The following is a description of a gene set: Reactome Pathway: KEAP1-NFE2L2 pathway species: Homo sapiens The KEAP1:NFE2L2 (KEAP1-NRF2, Kelch-like ECH-associated protein 1-Nuclear Factor (erythroid-derived 2)-like 2) regulatory pathway plays a central role in protecting cells against multiple homeostatic responses including adaptation to oxidative, inflammatory, metabolic, proteotoxic and xenobiotic stresses. The NFE2L2 transcriptome has been implicated in protection against many chronic diseases including cardiovascular, metabolic, neurodgenerative and respiratory diseases. In cancer, NFE2L2 plays a critical role in the metabolic reprogramming, directing metabolic intermediates into the Warburg and pentose phosphate pathways to support proliferative growth and redox homeostasis<br><br>KEAP1 is a redox sensor that together with CUL3/RBX1 forms part of an E3 ubiquitin ligase, which tightly regulates the activity of the transcription factor NFE2L2 by targeting it for ubiquitination and proteasome-dependent degradation. Oxidative modifications or electrophile adduct formation with redox-sensitive cysteines within KEAP1 renders this protein unable to target bound NFE2L2 for ubiquitination and allows newly translated NFE2L2 to accumulate within the cell and translocate to the nucleus where it can promote its transcriptional program.<br> part of: Cellular response to chemical stress, and this is the list of marker genes: CSNK2B, BRCA1, PSMD13 (proteasome 26S subunit, non-ATPase 13), SKP1, GSTA3, EP300, PSMC4, FBXL17, PSMA6, PSMD2, KEAP1, ADRM1, TRIM21, CSNK2A2 (NCBI Gene Id 650690), MUL1, AMER1, TALDO1, PSMD3, VCP, MIR155, PSMD7, NFKB1, PSMD6, SRXN1, X, SP1, PALB2, PRKCI, ABCF2, PDGFA, AREG, UBC, PRKCD, PSMB1, CDKN2A, GCLC, MIR196A1, MIRLET7C, PSMD14, MAFG, BACH1, PGD, PSMA2, EGF, DPP3, PSMD12, UBA52, PSMB2, PRKAA2, PSMA3, AKT1, TXN, CSNK2A1, ABCG2, UBXN7 (UBX domain protein 7), NPLOC4, RPS27A, G6PD, CHD6, NQO1, BCL2, CUL1, MAFK, MIRLET7B, PSMD1, CUL3, PSMA5, UBB, MAP1LC3B, IL8, AKT3, SQSTM1, PRDX1, CREBBP, PSMB3, IDH1, CCL2, BCL2L1, PSMA7, BTRC, SESN1, PSMA4, PSMC1 (NCBI Gene Id 5700), SESN2, GSK3B, ABCC3, SOD3, CDKN1A, MIR98, NFE2L2, SKP2, PSMB5, GSTA1, UFD1, PSMB7, ME1, GSR, PSMC6, GCLM, ATF4, HMOX1, MYC, AKT2, EIF2AK3, PSMC5, PSMD8, PSMB6 (proteasome 20S subunit beta 6), PSMC2, PSMD11, ABCC1, SEM1, NOTCH1, RBX1, PSMB4, SLC7A11, TKT, TXNRD1, PSMA1, PSMC3, RELA